Given this list of marker genes FOXC1, LCN2, KIF1A, ZIC1, BST2, CCL20, KANK4, PITX1, TFAP2A, SAA2, CXCL17, CDC20B, TFF3, DKK4, ESPN, S100A2, FOXA1 (NCBI Gene Id 3169), LTF, ALPG, CXCL5 (NCBI Gene Id 6374), SERPINA3, EPPK1, VIL1, HP, MALSU1, here is a description of the gene set: Genes up-regulated in cancer endometrium samples compared to the normal endometrium. from publication Wong YF, Cheung TH, Lo KW, Yim SF, Siu NS, Chan SC, Ho TW, Wong KW, Yu MY, Wang VW, Li C, Gardner GJ, Bonome T, Johnson WB, Smith DI, Chung TK, Birrer MJ (PMID 17043662) Endometrial cancer is the third most common gynecologic malignancy and the ninth most common malignancy for females overall in Hong Kong. Approximately 80% or more of these cancers are endometrioid endometrial adenocarcinomas. The aim of this study was to reveal genes contributing to the development of endometrioid endometrial cancer, which may impact diagnosis, prognosis and treatment of the disease. Whole-genome gene expression analysis was completed for a set of 55 microdissected sporadic endometrioid endometrial adenocarcinomas and 29 microdissected normal endometrium specimens using the Affymetrix Human U133 Plus 2.0 oligonucleotide microarray. Selected genes of interest were validated by quantitative real-time-polymerase chain reaction (qRT-PCR). Pathway analysis was performed to reveal gene interactions involved in endometrial tumorigenesis. Unsupervised hierarchical clustering displayed a distinct separation between the endometrioid adenocarcinomas and normal endometrium samples. Supervised analysis identified 117 highly differentially regulated genes (>or=4.0-fold change), which distinguished the endometrial cancer specimens from normal endometrium. Twelve novel genes including DKK4, ZIC1, KIF1A, SAA2, LOC16378, ALPP2, CCL20, CXCL5, BST2, OLFM1, KLRC1 and MBC45780 were deregulated in the endometrial cancer, and further validated in an independent set of 56 cancer and 29 normal samples using qRT-PCR. In addition, genes were differentially regulated in late-stage cancer, as compared to early-stage disease, and may be involved in tumor progression. Pathway analysis of the expression data from this tumor revealed an interconnected network consisting of 21 aberrantly regulated genes involved in angiogenesis, cell proliferation and chromosomal instability. The results of this study highlight the molecular features of endometrioid endometrial cancer and provide insight into the events underlying the development and progression of endometrioid endometrial cancer. species: Homo sapiens Human Gene Set: WONG_ENDMETRIUM_CANCER_UP